The following is a description of a gene set: Genes having at least one occurrence of the motif GSCCSCRGGCNRNRNN in the regions spanning 4 kb centered on their transcription starting sites. This matches the GTF3A transcription factor binding site V$AP2_Q3 (v7.4 TRANSFAC). species: Homo sapiens Human Gene Set: AP2_Q3, and this is the list of marker genes: EBAG9, PSMD1, TMEM132E-DT, FLI1, ADAM23, CAND1, C6orf62, NRF1, ZIC1, ETF1, CTSA, EIF4A1, STAB1, IL11, EML3, GORASP2, PIGO (NCBI Gene Id 84720), SSX2IP, DNAI1, PLAGL2, PHACTR3, UBE2B, CCDC136, CBLL1, FAM76A, INO80D, POLD4, NCOA6 (NCBI Gene Id 23054), ZBTB22, NCAPD3, DNAJC7, BARX1, RGS8, IGF1R, SH3BP5L, CDH24, C1QL2, ESRRA, UNC50, TMEM132E, TCF7, CHD4, FAM89B, TLN1, SMG1, TMEM208, APLP1, KCNN2, IER5L, DCAF1, CTCF, MAP3K6, KLF10, PURA, PTCHD1, LLGL2, CDK16, EPHB1, H1-0, FBXL14, OGA, IRS1, ATG9A, COL11A2, PURB (NCBI Gene Id 5814), C6orf89, BCL11B, SLC4A1, MECOM, ERF, SPOP, CSRNP2, PBRM1, XRCC6, PPM1E, MIB1, FGF8, CNNM1, YWHAQ, SPAST, PORCN, WNT1, ARL3, DSP, KCND1, RPS6KA3, TFAP2C, RAB35, MYO15A, MAT2A, LHX4, SPINK5, ACTL6B, VPS26B, SYT7, EIF4G2, NALF2, SALL1, MRPL40, NLGN3 (NCBI Gene Id 54413), SOX12, SLC30A3, KCNA6, MGLL, NR3C1, WNT10A, LCOR, ABHD1 (NCBI Gene Id 84696), MAP3K3, FAM53C, RRAS, CACNA1G, ELF4, PDE6D, PATZ1, PPP1CA, HIC1, ZBTB7A, CPSF4, RGMA (NCBI Gene Id 56963), NFAT5, HIRA, GPBP1 (NCBI Gene Id 65056), PDGFB, GABRA4, POU4F1, MYCN, SLC7A10, ANKZF1, TGFB1, ST3GAL5, ASIC2, LRRC36, PAIP2, TSPAN7, RASAL2, ST6GALNAC5, ZC3H10, MAPT, FAM78A, TBC1D10B (NCBI Gene Id 26000), SOX2, MNT, GPRC5B, CXXC5, MEX3B, CREB3, PITPNC1, HECTD1, RASGEF1A, CBLN4, FOXO3, BORCS5, VEGFB, HEBP2, HOXC10, SPACA6, PABPC1, ZNF576, SLC35D1, LHX6, ACSL3, E2F4, CAMTA2, UBTF, HEBP1, HEY1, CDK5R1, KAT7, CCDC9B (coiled-coil domain containing 9B), TRIM24, CDK9, POLH, UBE2L3, USF1, CHSY1, RIMS1, JADE1, WFDC3, NXPH4, EPC1, TENT5B, CLOCK, FBXL9P, CTDSP1, MIR17HG, PAX7, CNP, P4HA1, CRTAC1, WDTC1 (WD and tetratricopeptide repeats 1), NKX2-1, CACNG2, RNF220, RELB, ZNF70, MSI1, SLC12A4, RAP1GDS1, EPHA3, PPME1 (NCBI Gene Id 51400), ADRA2C, FGD1, GRM3, ARTN, MARCKSL1, RAB7A, NKIRAS2, NEURL2, CALHM2, UBL3, H1-10, GABBR2, ZNF335, KCNA1, TRIM33, MAF, HDLBP, DDB1, ROM1, PLCB3, POFUT1, SLC4A3, EMX2, SLITRK5, SFXN2, LIMK2, MOV10 (NCBI Gene Id 57723), DNTTIP1, RPL41, STAG2, GRIK3, FOXO1, LHX2, GAS7, XPO5, CHN2, FOSL2, POU4F2, LBX1, WNT3, RPS6KA4, ZNF385A, SPATA6 (spermatogenesis associated 6), TBX3, ETV4, PRDM16, MAFB, FXR2, SF1, KCNB2, PCIF1, ABCF2, PLXNC1, AMMECR1L